The following is a description of a gene set: Intra-Golgi and retrograde Golgi-to-ER traffic species: Mus musculus Mouse Gene Set: REACTOME_INTRA_GOLGI_AND_RETROGRADE_GOLGI_TO_ER_TRAFFIC, and this is the list of marker genes: Tubb6, Copz1, Surf4, Napg, Kif1a, Sec22b, Dynll2, Copz2, M6pr, Kif15, Stx5a, Napb, Tuba1b, Ric1, Kif23, Rint1, Gcc2, Ykt6, Bicd2, Arfgap3, Kif19a, Actr10, Pla2g6, Cyth1, Kifc5b, Kif16b, Gcc1, Dctn3, Zw10, Kif27, Klc2, Dync1i1, Vps52, Cog5, Tmed3, Capza3, Kif18a, Tubb2a, Actr1a, Alpi, Plin3, Kif21a, Rab6a, Snap29, Dctn5, Kif28 (kinesin family member 28), Kif20a, Vamp3, Kif20b, Stx16, Tgoln1, Arf3, Pafah1b1, Tuba1c, Sys1, Capzb, Copb1, Klc3, Tmed2, Cyth2, Klc1, Vps53, Kif1c, Arf1, Pafah1b3, Tuba4a, Kif3c, Capza2, Rab18, Rhobtb3, Nsf, Cyth3, Kifc2, Kif22, Tmed7 (NCBI Gene Id 76112), Kif6, Cyth4, Klc4, Kif3a, Vti1a, Tuba1a, Akp3, Arf4, Cog4, Arf5 (ADP-ribosylation factor 5), Rgp1, Rab9, Gosr2, Usp6nl, Kifc1, Rab6b, Gosr1, Kif13b, Cope, Stx6, Tubb2b, Rab36, Dctn6, Arl1, Arfip2 (NCBI Gene Id 76932), Kif12 (kinesin family member 12), Rab3gap1, Scoc, Tuba3b, Cog1, Copa, Cog2, Kif2a, Tubal3, Copb2, Agpat3, Dynll1, Rab1a, Rab43, Galnt2, Kif18b, Cog7, Dync1i2, Arfgap1, Kifap3, Napa, Igf2r, Tmed9, Dctn2, Pla2g4a, Rab33b, Copg2, Rabepk, Use1, Cog6, Kif26a, Rab1b, Gbf1, Galnt1, Vamp4, Tmed10, Kif3b (kinesin family member 3B), Golga1 (NCBI Gene Id 99313), Rab39, Kif26b, Tubb4a, Kif9, Rab30, Rab9b, Kdelr1, Copg1, Kif2b, Tubb1, Vps45, Trip11, Arfrp1, Dync1h1, Cog3, Tubb3, Kif11 (kinesin family member 11), Kif5b, Kif5a, Bicd1, Dctn4 (dynactin 4), Kif2c, Tmf1, Dync1li2, Tuba3a, Dync1li1, Rab3gap2, Bnip1, Stx18 (NCBI Gene Id 71116), Kif4, Tuba8, Vps54, Nbas, Cog8, Kdelr3, Kdelr2, Vps51, Dctn1, Kif21b, Arcn1 (archain 1), Golga4 (golgin A4), Racgap1, Kif1b, Tubb4b, Alppl2, Cenpe, Bet1l, Arfgap2, Pafah1b2 (NCBI Gene Id 70308)